Given this list of marker genes MIR7-3HG, MTND5P11, MT-RNR1, MTCO3P12, MT-TF, RBMX, EEF1A1, SNORD61, RBMXP2, MIR7-3, here is a description of the gene set: Human Gene Set: RBMX_TARGET_GENES species: Homo sapiens Genes containing one or more binding sites for (RBMX) in their promoter regions (TSS -1000,+100 bp) as identified by GTRD version 20.06 ChIP-seq harmonization. from publication Yevshin I, Sharipov R, Kolmykov S, Kondrakhin Y, Kolpakov F (PMID 30445619)